The following is a description of a gene set: Human Gene Set: HP_LIMBAL_DERMOID species: Homo sapiens A benign tumor typically found at the junction of the cornea and sclera (limbal epibullar dermoid). Limbal dermoid, and this is the list of marker genes: DACT1, AKT1, KRAS, PTEN, SF3B2, FGFR1, SALL1, PLCB4